The following is a description of a gene set: species: Homo sapiens Absence or abnormal closure of the choana (the posterior nasal aperture). Most embryologists believe that posterior choanal atresia results from a failure of rupture between the 35th and 38th day of fetal life of the partition which separates the bucconasal or buccopharyngeal membranes. The resultant choanal atresia may be unilateral or bilateral, bony or membranous, complete or incomplete. In over 90 per cent of cases the obstruction is bony, while in the remainder it is membranous. The bony type of atresia is commonly located 1-2 mm. anterior to the posterior edge of the hard palate, and the osseous septum varies in thickness from 1 to 10 mm. In the membranous form of choanal atresia the obstruction usually occurs further posteriorly. In approximately one third of cases the atresia is bilateral. Choanal atresia Human Gene Set: HP_CHOANAL_ATRESIA, and this is the list of marker genes: SRPX2, FOXH1, SOX9, PERCC1, NODAL, DISP1, FGF8, LMNA, GRIN2B, FANCC, ZIC2, NIPBL, GLI3, FANCG, SALL4, SEC24C, FANCA, XRCC2, TP63, SMC3, ERF, FANCM, SLC37A4, RPL11, CDH1, IGBP1, NBN, SEMA3E, FANCI, FAM20C, EFTUD2, POLR1A, RAD51, RAD21, COMT, BCR, SALL1, FGFR3, HDAC8, DHCR7, UBE2T, PI4KA, ITCH, POLR1D, PALB2, NFIX, GLI2, OFD1, MAD2L2, TXNL4A, WNT3, ANTXR1, RAD51C, HIRA, POLR1B, SLC12A2, GAS1, BRCA2, BRIP1, KMT2D, FOXE1, ARVCF, RFWD3, FANCD2 (NCBI Gene Id 2177), WBP11, TWIST1, UFD1, ZNF335, MBTPS2, SHH, DCHS1, DLL1, CDC45, FANCB, FANCF, TAF6, MED12, FANCL, GLIS3, JMJD1C, SUFU, POR, ERCC4, DHODH, TBX1, BRD4, SMC1A, SPINT2, FGFR2, BRCA1, CHD7, PAICS, POLR1C, SIX3, FGF10 (fibroblast growth factor 10), KDM6A, CRKL, TGIF1, FANCE, PTDSS1 (NCBI Gene Id 9791), FAT4, SMCHD1 (structural maintenance of chromosomes flexible hinge domain containing 1), TCOF1, RREB1, PTPN14, PTH1R, CDON, IRF6, MAPK1, RPS26, SLX4, EPCAM, TCTN3, WAC, GP1BB, ADGRG1, PTCH1, FGFR1, CRIPTO, CHD6, RERE, ZMPSTE24, ARID1B, USP9X